The following is a description of a gene set: species: Homo sapiens Human Gene Set: KEGG_MEDICUS_REFERENCE_P15_CELL_CYCLE_G1_S p15-Cell cycle G1/S. Pathway ID: N00090. Pathway type: Reference. Pathway class: nt06267 Small cell lung cancer. Pathway Definition from KEGG: (MYC+MAX) -| ZBTB17 => CDKN2B -| (CCND+CDK4/6) -> RB1 // E2F, and this is the list of marker genes: CDKN2B, CDK6, E2F1, ZBTB17, CCND1, CDK4 (cyclin dependent kinase 4), CCND3, CCND2, MAX, E2F3, RB1, MYC, E2F2